Given this list of marker genes Nrcam, Lmtk3, Ror2, Llgl1, Hapln2, Syt4, Cd40, Eps8, Ngdn, Spast, Dync1i1, Epha4, Pebp1, Sdc3, Robo1, Cacna1b, Ngef, Nfasc, Adgrl3, Fgf13, Drd1, Anxa3, Wdfy3, Hcn4, Ulk1, Stat1, Kif3a, Smn1, Whrn, Mtpn, Cd200, Fscn3, Hnrnpk, Gper1, Pnmt, Stxbp1, Ilk, Fez1, L1cam, Terf2, Map1b, Cyp17a1, Crhbp, Orai1, Atp6v0d1, Evx1, Myot (NCBI Gene Id 80644), Myo1a, Ap3b1, Myo5a, Acte1, Bloc1s1, Igf2bp1, Eno1b, Tprg1l (transformation related protein 63 regulated 1 like), Kcnab2, Dynlt1a, Acadm, Arl8b, Camk2d (NCBI Gene Id 77170), Prkcb, Eif4g2, Slc17a8, Rpl26, Cplx4, Cldn5, Marcks, Sbf2, Calb1, Flna, Coro1a, Cib1, Prph (peripherin, NCBI Gene Id 19132), Ror1, Pde2a, Atg5, Chrna7, Crmp1, Actbl2, Fkbp4, Unc5c, Dync1h1, Ache, Glra1, Tmod2, Itga2, Ghrl, Syde1, Nptn, Atp5mc1, Nmu, N4bp3, Ptprz1, Mbp, Syp, Hmcn2, Cacng2, Clcn3, Atat1, Atp1a3, Crtac1, Rtn4rl2, Ank3, Cst3, Adcy10, Jam2, Ager, Ntng2, Cbl, Ermn, Ap3s1, Gsk3b, Stx1a, Ccl2, Kif21a, Ntsr1, Klhl20, Plekhg5, Bcan, Syt13, Ndrg2, Grk2, Bcr, Chrna10, Gars1, Adgrl1, Optn, Nos1, Prnp, Cacna1c, Kcna3, Crhr2, Trpm7, Hap1, Mgarp, Il31ra, Ap1s1, Sema6a, Grip1, Gsto1, Zfyve27, Cobl, Ppp1r9a, Nefl, Dagla, Smo, Tspoap1, Txnrd2, Map9, Lpar3, Txn1, Gabra2, Htt, Nrn1l, Bsg, Elk1, Cngb1, P2rx3, Eno2, Fzd5, Exoc3, Rab27b, Azin2, Septin14, Slc8a1, Arpc2, Oprd1, Grm4, Ccsap, Mylk2, Atoh7, Abr, Grm7, Calca, Dcx, Sphk1, Src, Rac3, Scn11a, Lrrtm1, Sirt1, Htr3b, Maf1, Gria1, Cnga1, Grin2b, Unc13b, Ccdc120 (NCBI Gene Id 65947), Taok2, Ccn3, Nf1, Impa1, Cd200l2, Dyrk1a, Cdh1, Gdpd5, Gripap1, Ppt1, Scn3a, Ndel1, Nrsn1, Kcnma1, Tpm3, Trak1, Emb, Cyth2, Adcy9, Pnoc, Scn10a, Prkaa2 (NCBI Gene Id 66516), Cntnap2, Fam168b, Npcd, Agbl4, Unc13c, Dhx36, Ptpn5, Adra2c, Ncmap (NCBI Gene Id 352981), Slc38a7, Tsc1, Exoc7, Tpx2, Ngfr, Katnb1, Scn8a, Gria4, Kcnq2, Flrt3, Ptprf, Adcy1, Tbc1d24, Kcnc2, Caly, Scn5a, Crh, Cnga3, Nrg1, Ptprn, Bcar1, Kirrel3, Tmem108, Stau2, Igsf8, Gabbr1, Reg1, Itpr2, Park7, Car2, Mypn, Plec, Slc6a2, Aatk, Atl1, Chrm2, Cntn6, Atp2b3, Disc1 (NCBI Gene Id 640053), Map1lc3b, Mapk8ip1, Ireb2, Scn2b, Syt2, Hmbs, Kcna6, Erc2, Aak1, Rtn4r, Trpm1, Grik5, Abi1 (abl interactor 1), Gabrb3, Hcn2, Vps16, Kif20b, Htr3a, Slc38a1, Mapk8, Slc30a3 (NCBI Gene Id 22784), Eif2b2, Slc6a1, Gabrg2, Calml3, Kif5c, Mapk1, Hnrnpr, Rapgef4, Ap3m2, Arl8a, Phb2, Apbb1, Lrp8, Afdn, Cacng7, Slc9a6, Orai2, Gria2, Lrrk2, Slc6a3, Tgfb2, Inpp5j, Ncs1, Itga3, Ctnna2, Pak1, Kif13b, Robo2, Hcfc1, Map3k12, Grm3 (glutamate receptor, metabotropic 3), Lsm1, Fez2, Cdh9, Cfh, Mycbp2, Nrgn, Grik3, Dctn2, Boc, Rxra, Nrtn, Slc38a8, Cplx2, Got1, Kcnk2, Fzd3, Chat, Opn1sw, Amph, Polg, Dnm2, Dpysl3, Lmtk2, Maco1, Dscam, Dock7, Cpne6, Cdkl5, Hsbp1, Tanc1, Syap1, Slc4a10, Esr1, Mdga1, Cabp1, Aldh1a1, Ar, Ppfia2 (NCBI Gene Id 327814), Dmd, Nefm, Mgll, Rhoa, Cntnap1, Prrt2 (proline-rich transmembrane protein 2), Bdnf, Stx1b, Adra2a, Slc17a7, Scgn, Calb2, Ptbp2, Pcsk1, Kcnc3, Map1a, Aldoc, Cckar, Eno1, Avil, Nectin1, Sybu, Myo6, Cxcr4, Casp6 (NCBI Gene Id 12368), Htr7, Chrm3 (NCBI Gene Id 12671), Dnm1, Blvrb, Cck, Nrxn1, Insrr, Sigmar1, Kcnq3, Cdk5, Inpp5f, Epha5, P2rx2, Nrp2, Cnr1, Amfr, Htr2a, Drd4, Mpp4, Rogdi (NCBI Gene Id 98005), Kif1b, Dpysl2, Ap3s2, Pcdh9, Trim46, Atg7, Sncb, Brsk1, Ywhae, Ppp2ca, Adora1, Gdi1, Snap91, Npff, Shtn1, Adnp, Shh, Gc, Bloc1s2, Gnrh1, Katna1, Nts, Spta1, Ntrk3, Npy1r, Srcin1, Thy1, Lrp2, Stmn4, Nfib, Copg2, Kcnc1, Cplx3, Cd2ap, Ntrk1, Kcnb1, Syt7, Sptbn1, Anxa5, Tulp1, Srsf10, Dvl1, Dctn1, Ssh1, Kcna1, Map6, Dip2b, Rgs7bp, Nmnat3, Cdk5r2, Ntf5, Cadm1, Ephb2, Pals1, Hcn1, Arpc3, Hsp90aa1, Grin1, Adcy8, Th, Gpm6a (NCBI Gene Id 234267), Cd200l1, Serpinf1, Cttn, Omp, Htr1a, Tnfrsf1a, Septin6 (septin 6), Kcnq5, Cntnap3, Pgr (NCBI Gene Id 270116), Emx2, Slc1a2, Myh10, Myh14, Armcx3 (NCBI Gene Id 71703), Irx3, Madd, Bace1, Mtmr2, Elavl4, Prkcz, Dst, Tnk2, Tiam2, Canx, Glul, Drd2, Scn9a, Oprm1, Calcr, Gria3, Kcnj6, Crcp, Mast1 (NCBI Gene Id 80677), Syt8, Bag2, Gap43 (growth associated protein 43), Pum1, Basp1, Stmn3, Dlg4 (discs large MAGUK scaffold protein 4), Ncdn, Hdac6 (histone deacetylase 6), C4b, Npy, Otx2, Dnm3, Clasp2, Tenm3, Rab5a, Gad2, Prkn, Hcn3, Kif1a, Grm1, Adam10, Spg11, Trak2, Scn1b, Acap3, Kif3c, Pcdhgb1, Cdh8, Fkbp15, Slit2, Setx, Chrm1, Ncam1, Cntn5, Calm1, Slc12a6, Dbn1, Slc8a3, Rapgef3, Kcna2, Sptbn4, C4a, Bloc1s6, Dcc, Dixdc1, Slc8a2, Usp9x, Ap3m1, Unc80, Grm2, P2rx4, Pafah1b1, Agtpbp1, Alk, Trpa1, Spock1, Scn1a, Agrn, Mapt, Lgi1, Rnf6 (ring finger protein (C3H2C3 type) 6), Exoc4 (exocyst complex component 4), Fkbp1a, Unc13a, Gprin1, Ephb1, Reln, Dscaml1, Mag, Map2k1, Rangap1, Dynll1, Dclk1, Lrrc4b, Eea1, Scn2a, Ush2a, Sod1 (superoxide dismutase 1, soluble), Cldn11, Lgi3, Syn1, Slc38a2 (NCBI Gene Id 67760, solute carrier family 38, member 2), Gfra1, Tubb3, Septin5, Comt, Dlg1, Cpt1c, Prkaa1 (protein kinase, AMP-activated, alpha 1 catalytic subunit), Rimbp2 (NCBI Gene Id 231760), Lamp5, Ap3d1, Hspa8, Atp7a, Sptan1 (NCBI Gene Id 76356), Syt1, Snap25, Slc1a7 (NCBI Gene Id 242607), Ddc, Gabrd, Cryab, Ptch1, Ophn1, Borcs5, Slc5a7, Kcnj11, Itga4, Kif3b, Tsc2, Cbarp, Pygb, Pdyn, Pcp4, Ppfia1, Adcyap1, Septin4, Ssna1, Limk1, Pvalb, Hif1a, Clcn2, Kif5a, Slc17a6, Trpc5, Ptprs, Git1, Kcnh1, Cfl1, Ppp1r2, Aqp1, Gad1, Frmd7, Il1rapl1, Robo3, Aurka (NCBI Gene Id 99385), Syt5, Git2, Fscn1, Sncg, Zpr1, Arpc5, Dab2ip, Map7, Myc, Mir133b, Tanc2 (tetratricopeptide repeat, ankyrin repeat and coiled-coil containing 2), Mul1, Nav1, Copa, Tor1a, Tnfrsf1b, Rgs10, Dynlt1f, Bloc1s5, Stmn2, Prkcg (NCBI Gene Id 18752), Cyfip1, C1ql1, Ttyh1, Creb1, Stx3, Exoc6, Ap3b2, Ptprk, Adam11, Dicer1, Kif5b, Tgfb1, Sarm1, Hsp90ab1, Bloc1s3, Dtna, Tiam1, Septin8, Lrp1, Slc18a3, Rufy3, Sri, Nefh, Scn4a, Brsk2, Gldn, Nek3, Actg1, Synj1, Timp2, Cadm2, Pawr, Adrb2, Stim1, Pink1, Ranbp1, Insr, Zc3h14, Dynlt1b, Slc32a1, Slc1a1, Nog, Septin11, Tac1, Cntn2, Wdr47, Prkca (NCBI Gene Id 18750), Hdac5, Cad, Mapk8ip3, Ptprn2, Ldlrap1, Rab21, Kif21b, Actb, Bloc1s4, Igsf9, Zfp804a, Kcnc4, Grik1, Ngf, Ncam2, Bsn, Tnn, Ctnnd1, Fmr1, Shank2, Crp, Tenm2, Nectin3 (nectin cell adhesion molecule 3), Uchl1, Mme, Ang, Olfm1, Snapin, Cpeb4, Ucn, Vim, Calm2, Synpo, Auts2, Adam21, Als2, Il1r1, Dgki, Oprk1, Igf1r, Rap1gap, Adam22, Synj2, Cplx1, Neto1, Map2k4, Kcna4, Ntf3, Dlg2, Kif1c, Iqgap1, Prss12, Rab3a (RAB3A, member RAS oncogene family), Klhl24, Adora2a, Kcnk4, Homer1, Cdk5r1, Slc4a8, Abl1, Mical1, Ret, Ntm, Klc1, Sh2d3c, Trpv2, Plxnd1, Lrrc7, App, Hpca, Map4, Atp6ap2, Dlg3, Gsk3a, Cntf, Dbh, Pacsin1, Mt3, Psen1, Rin3, Myo9a, Tubb4a, Mir18, Casr, Twf2, Arhgap4, Penk, Slc2a13, Dtnbp1, Cyp19a1, Grik4, Chrm4, Snx18, Neo1, Btbd8, Uhmk1, Pdgfra, Tmem151a, Dag1, Atg16l1, Gjc2, Iqschfp, Atp1a1, Tpgs1, Syt11 (NCBI Gene Id 99745), Ppp1r9b, Calm3, Ptk2b, Tmem230, Ank1, Fxr1, Rasgrf1, Palld (NCBI Gene Id 72333), Hspb1, Slc18a1, Cables1, Slc18a2, Palm, Grik2, Myoc, Prtg, Map2, Nmnat2, Myo1d, Ucn3, Camk2a, Ighmbp2, Vstm5, Dynlt1c (dynein light chain Tctex-type 1C), Snca, Nlgn2, Bin1, Bmpr2, Oxt, Alcam, Mrgpra3, Apc, Arhgef7, Csnk1e, Ghrh, Lrfn3, Amigo1, Ctsz, Nexn, Epb41l3, Nin, Opn4, Septin7, Lrig2, Trpv4, Kcnip3, Gabrr2 (gamma-aminobutyric acid type A receptor subunit rho 2), Spg7, Clu, Atcay, Drd5, Prex1, Cntn1, Nrp1, Tshz3, Grk3 (G protein-coupled receptor kinase 3), Cpeb1 (cytoplasmic polyadenylation element binding protein 1), Grin2a, Pard6a, Mink1, Cxadr, Tpbg, Smurf1, Abitram, Necab2, Kcnab1, Htr1b, Sirt2, Ntrk2, Elfn1, C9orf72, Itsn1, Pclo, Sema3a, Exoc8, P2rx7, Pard3, here is a description of the gene set: The long process of a neuron that conducts nerve impulses, usually away from the cell body to the terminals and varicosities, which are sites of storage and release of neurotransmitter. Mouse Gene Set: GOCC_AXON species: Mus musculus